The following is a description of a gene set: species: Homo sapiens The gene expression program underlying the specification of human cell types is of fundamental interest. The study authors generated human cell atlases of gene expression and chromatin accessibility in fetal tissues. For gene expression, the study authors applied three-level combinatorial indexing to >110 samples representing 15 organs, ultimately profiling ~4 million single cells. The study authors leveraged the literature and other atlases to identify and annotate hundreds of cell types and subtypes, both within and across tissues. Our analyses focused on organ-specific specializations of broadly distributed cell types (such as blood, endothelial, and epithelial), sites of fetal erythropoiesis (which notably included the adrenal gland), and integration with mouse developmental atlases (such as conserved specification of blood cells). These data represent a rich resource for the exploration of in vivo human gene expression in diverse tissues and cell types. from publication Cao J, O'Day DR, Pliner HA, Kingsley PD, Deng M, Daza RM, Zager MA, Aldinger KA, Blecher-Gonen R, Zhang F, Spielmann M, Palis J, Doherty D, Steemers FJ, Glass IA, Trapnell C, Shendure J (PMID 33184181) Human Gene Set: DESCARTES_FETAL_EYE_RETINAL_PROGENITORS_AND_MULLER_GLIA Marker genes curated from the annotated cluster as represented in the Descartes Human Gene Expression During Development database., and this is the list of marker genes: FOXN4, L1TD1, ADGB, DNAH11, FAM72A, MYB, CLVS1, CASC17, NEIL3 (NCBI Gene Id 55247), OPTC, DEPDC1-AS1, GDPD2, PCYT1B, CDC25C, GABRG3, C10orf88B